Given this list of marker genes Elavl4, Nudt21, Zfp36l3, Elavl1 (ELAV like RNA binding protein 1), Mir466l, Rbm24, Elavl3, Mex3d, Rbms3, Arid5a, Fxr1, Zc3h12a, Cpeb3, Zfp36l1, Zfp36l2, Hnrnpa0, Khsrp, Cpeb2, Ilf3, Dhx36, Cpsf1, Zfp36, Exosc9, Exosc4, Tial1, Exosc7, Cpeb1, Hnrnpd, Exosc8, Apobec1, Ago2, Tia1, here is a description of the gene set: Binding to a region containing frequent adenine and uridine bases within the 3' untranslated region of a mRNA molecule or in pre-mRNA intron. The ARE-binding element consensus is UUAUUUAUU. ARE-binding proteins control the stability and/or translation of mRNAs. Mouse Gene Set: GOMF_MRNA_3_UTR_AU_RICH_REGION_BINDING studied in species Mus musculus